Given this list of marker genes Ube2n, Birc3, Tab3, Cyld, Casp2, Mapk14, Mapk12, Tab1, Casp8, Ubb, Map2k6, Mapk13, Tab2, Mapk11, Casp4, Casp9, Casp1, Tnfaip3, Rps27a, Ube2v1, here is a description of the gene set: This event has been computationally inferred from an event that has been demonstrated in another species.<p>The inference is based on the homology mapping from PANTHER. Briefly, reactions for which all involved PhysicalEntities (in input, output and catalyst) have a mapped orthologue/paralogue (for complexes at least 75% of components must have a mapping) are inferred to the other species. electronically inferred by orthology from the curated human pathway part of: Nucleotide-binding domain, leucine rich repeat containing receptor (NLR) signaling pathways Reactome Pathway: NOD1/2 Signaling Pathway species: Mus musculus